Given this list of marker genes RNF11, SLC2A4, PFKFB1, NRIP1, CBX4, ALAD, AP3S1, PC, TST, PLA2G6, TPP2, DHRS3, AOC3, CFD, SELENBP1, IDH1 (isocitrate dehydrogenase (NADP(+)) 1), ORM1, AQP7, IRX3, ADIPOQ, RETN, PXMP2, RASD1, APOC4, PPARG, LPL, FASN, MMUT, IDH3G, FXYD1, GPAM, HIPK2, HK2, HSD17B4, CIB2, RGS2, ABCD2, ADRB3, CDKN2C, here is a description of the gene set: studied in species Mus musculus Troglitazone (TGZ), a member of the thiazolidinedione class of anti-diabetic compounds and a peroxisome proliferator activator receptor-gamma (PPAR-gamma) agonist, restores systemic insulin sensitivity and improves the full insulin resistance syndrome in vivo. The mechanisms underlying its in vivo function are not understood. Here we investigated the potential functional interaction between PPAR-gamma and NF-kappaB in adipocytes. We show that TGZ selectively blocked tumor necrosis factor-alpha-induced and NF-kappaB-dependent repression of multiple adipocyte-specific genes and induction of growth phase and other genes. This occurs without interfering with NF-kappaB expression, activation, nuclear translocation, or DNA binding and without suppressing NF-kappaB-dependent survival signals. Notably, the expressions of some tumor necrosis factor-alpha-induced genes in adipocytes were unaffected by PPAR-gamma activation. In reporter gene assays in HeLa cells, ectopic expression of PPAR-gamma abolished induction of a NF-kappaB-responsive reporter gene by the p65 subunit (RelA) of NF-kappaB, and the inhibition was further enhanced in the presence of TGZ. Conversely, overexpression of p65 inhibited induction of a PPAR-gamma-responsive reporter gene by activated PPAR-gamma in a dose-dependent manner. The inhibitory effect was independent of the presence of NF-kappaB-binding sites in the promoter region. Other NF-kappaB family members, p50 and c-Rel as well as the S276A mutant of p65, blocked PPAR-gamma-mediated gene transcription less effectively. Thus, p65 antagonizes the transcriptional regulatory activity of PPAR-gamma in adipocytes, and PPAR-gamma activation can at least partially override the inhibitory effects of p65 on the expression of key adipocyte genes. Our data suggest that inhibition of NF-kappaB activity is a mechanism by which PPAR-gamma agonists improve insulin sensitivity in vivo and that adipocyte NF-kappaB is a potential therapeutic target for obesity-linked type 2 diabetes. from publication Ruan H, Pownall HJ, Lodish HF (PMID 12732648) Adipocyte abundant genes down-regulated in 3T3-L1 cells (fibroblasts induced to differentiate to adipocytes) in response to troglitazone and TNF. Human Gene Set: RUAN_RESPONSE_TO_TNF_TROGLITAZONE_DN